The following is a description of a gene set: Genes affected by epigenetic aberrations in prostate cancer. Prostate cancer is the most common noncutaneous malignancy and the second leading cause of cancer death among men in the United States. DNA methylation and histone modifications are important epigenetic mechanisms of gene regulation and play essential roles both independently and cooperatively in tumor initiation and progression. Aberrant epigenetic events such as DNA hypo- and hypermethylation and altered histone acetylation have both been observed in prostate cancer, in which they affect a large number of genes. Although the list of aberrantly epigenetically regulated genes continues to grow, only a few genes have, so far, given promising results as potential tumor biomarkers for early diagnosis and risk assessment of prostate cancer. Thus, large-scale screening of aberrant epigenetic events such as DNA hypermethylation is needed to identify prostate cancer-specific epigenetic fingerprints. The reversibility of epigenetic aberrations has made them attractive targets for cancer treatment with modulators that demethylate DNA and inhibit histone deacetylases, leading to reactivation of silenced genes. More studies into the mechanism and consequence of demethylation are required before the cancer epigenome can be safely manipulated with therapeutics as a treatment modality. In this review, we examine the current literature on epigenetic changes in prostate cancer and discuss the clinical potential of cancer epigenetics for the diagnosis and treatment of this disease. Human Gene Set: LI_PROSTATE_CANCER_EPIGENETIC from publication Li LC, Carroll PR, Dahiya R (PMID 15657340) species: Homo sapiens, and this is the list of marker genes: CXADR, LAMC2, CCND2, CAV1, GSTP1, MGMT, EDNRB, RARRES1, KLK3, PXMP4, CDKN2A, ESR1, PTGS2, CD44, CDH1, DDX53, AR, DAB2IP, HPSE, DAPK1, ESR2, PLAU, APC, ABCB1, VDR, RARB, HIC1, LAMA3, CDH13, CPA3, RASSF1, LAMB3